Given this list of marker genes Mamld1, Stat4, Tfap2c, Hs2st1, Gpc4, Ptgfrn, Dgkb, Cdon, Chst2, Pcdh19, Mt3, Sfrp1, Dmrta2, Gm29260, Gm23887, Kat6b, Smpdl3b, Efnb1, Galnt16, Emx2, Fzd9, Rad51c, Jph1, Fut9, Ttyh3, Nwd1, Bcan, Otx1, Drd3 (NCBI Gene Id 13490), Rgs20, Gm25630, Rab26, Gm32592, Ankmy1 (ankyrin repeat and MYND domain containing 1), Dmrta1, Gm35040, Gm13584, Emx2os, Gpc1, Actr3b, Tnfrsf19, Tshr, AI849053, Ostm1, Id4, Gm15577, Creb5, Gm37004, here is a description of the gene set: Mouse Gene Set: DESCARTES_ORGANOGENESIS_PREMATURE_OLIGODENDROCYTE Mouse Organogenesis Cell Atlas (MOCA) DE_gene_main_cluster.csv, fold.change>=1.5, qval<0.05, pval<0.05 studied in species Mus musculus from publication Cao J, Spielmann M, Qiu X, Huang X, Ibrahim DM, Hill AJ, Zhang F, Mundlos S, Christiansen L, Steemers FJ, Trapnell C, Shendure J (PMID 30787437)